Given this list of marker genes Ern2, Dbr1, Mblac1, Pop4, Ybey, Drosha, Rnaset2b, Ern1, Zc3h12b (zinc finger CCCH-type containing 12B), Abce1, Nudt16, Dicer1, Apex1, Ear14, Ago4, Rcl1, Elac1, Zc3h12d, Ago2, Fen1, Zc3h12a, Rnasek, Endov, Ankzf1, Tmbim6, Lactb2, Pop5, Khnyn, Cwf19l1, Slfn9, Pld6, Prorp, Tsen34, Tsnax, Rpp21 (ribonuclease P 21 subunit), Endog, Rpp30, Slfn8, Pop7, Nudt16l1, Nudt16l2, Endou, Elac2, Rida, Piwil1, Rnase1, Rnaseh2a, Tsen2, Rnaseh1, Rpp14, Rnaset2a, Nudt12, Rpp40, Snd1 (staphylococcal nuclease and tudor domain containing 1), Rpp38, Rnase2b (ribonuclease, RNase A family, 2B (liver, eosinophil-derived neurotoxin)), Nynrin, Nob1, Rpp25, Slfn14, Mrpl44, Ints11, Ago3, Piwil4, Pop1, Cpsf3, Smg6, Zc3h12c, Exog, Piwil2, here is a description of the gene set: species: Mus musculus Catalysis of the hydrolysis of ester linkages within ribonucleic acid by creating internal breaks. Mouse Gene Set: GOMF_RNA_ENDONUCLEASE_ACTIVITY